The following is a description of a gene set: The postradiation tumor escape signature: genes up-regulated in tumors from irradiated stroma vs those from non-irradiated stroma. studied in species Mus musculus Human Gene Set: MONNIER_POSTRADIATION_TUMOR_ESCAPE_UP Radiotherapy is widely used to treat human cancer. Patients locally recurring after radiotherapy, however, have increased risk of metastatic progression and poor prognosis. The clinical management of postradiation recurrences remains an unresolved issue. Tumors growing in preirradiated tissues have an increased fraction of hypoxic cells and are more metastatic, a condition known as tumor bed effect. The transcription factor hypoxia inducible factor (HIF)-1 promotes invasion and metastasis of hypoxic tumors, but its role in the tumor bed effect has not been reported. Here, we show that tumor cells derived from SCCVII and HCT116 tumors growing in a preirradiated bed, or selected in vitro through repeated cycles of severe hypoxia, retain invasive and metastatic capacities when returned to normoxia. HIF activity, although facilitating metastatic spreading of tumors growing in a preirradiated bed, is not essential. Through gene expression profiling and gain- and loss-of-function experiments, we identified the matricellular protein CYR61 and alphaVbeta5 integrin as proteins cooperating to mediate these effects. The anti-alphaV integrin monoclonal antibody 17E6 and the small molecular alphaVbeta3/alphaVbeta5 integrin inhibitor EMD121974 suppressed invasion and metastasis induced by CYR61 and attenuated metastasis of tumors growing within a preirradiated field. These results represent a conceptual advance to the understanding of the tumor bed effect and identify CYR61 and alphaVbeta5 integrin as proteins that cooperate to mediate metastasis. They also identify alphaV integrin inhibition as a potential therapeutic approach for preventing metastasis in patients at risk for postradiation recurrences. from publication Monnier Y, Farmer P, Bieler G, Imaizumi N, Sengstag T, Alghisi GC, Stehle JC, Ciarloni L, Andrejevic-Blant S, Moeckli R, Mirimanoff RO, Goodman SL, Delorenzi M, Rüegg C (PMID 18794119), and this is the list of marker genes: RPAP1, RRP8, PRCP, PTPN11, FAM149A, INTS13, ZNF267, LRRC14, CGNL1, RAMP3, SCIN, AKAP1, PRKAR2B, SLC66A2, CAMK2D, KAT2A, SLC25A10, SPTBN1, TXNRD1, INTS2, SMAD1, CCNT1, SRM, TADA2B, XPO5, MAN1A1, G3BP2, PABPN1, RUNDC1 (NCBI Gene Id 146923), XPO4, SLC48A1, YAP1, FASTKD1, DHX9, FAM98A, NEMF, WIPF2, SLC25A44, PPM1F, AHRR, GON4L, NQO1, BNC2, HGH1, ZFYVE27, PNN, AK1, C5orf22, VCAN, ZNF335, TARDBP, SFPQ, NNMT, SLC39A6, FOSL1, FAAP24, EEIG1, MYBBP1A, GPC1, EREG (epiregulin), LRIG1, AQP5, ZKSCAN3, PDPR, AKR1B1, NHLRC2, ENPP2, HMGA1, ADIPOR1, AIRIM, OTUD7B, CRHR1 (corticotropin releasing hormone receptor 1), ZNF106, LONP1, RAPGEF6, ZMYND19, CLEC1A, CCL5, ALG10, CXCL6, DYNLL2, ERGIC1, MYD88, TNFAIP2, IL18R1, MSI2, CCDC93, MYBL2, ANKRD13A, DHX33, SMIM36, TFDP2 (transcription factor Dp-2, NCBI Gene Id 7029), IPO4, SEC22C, HIPK1, OXR1, ALKBH1, CLBA1, ZNF136, USP20, PRKCA, ATP1B1, DUSP9 (dual specificity phosphatase 9), NOA1, GREM1, GATAD2A, TSR1, NPLOC4, NAA25, SSX2IP, NOP9, ZNF121, ASS1, ASPH, AEBP1, WDR46, ZDHHC3, PTGS1, MLLT6, FAM53C, FAM83G, HNRNPK (NCBI Gene Id 3190), OTUD4, RAB5C, NMT2, SLC7A6, MAP2K3 (NCBI Gene Id 92079), DEPTOR, SMURF1, UBIAD1, SH3PXD2A, AVEN, RAPGEF1 (NCBI Gene Id 2889), TANGO6, SYNCRIP (synaptotagmin binding cytoplasmic RNA interacting protein), MTMR9, MYO10, MRPL15, AGO2, FDX1, PDCD11, LHFPL6, PMM2, MEI1, BAP1, ETV6, PABPC4, PDPN, KCNU1 (potassium calcium-activated channel subfamily U member 1), SNHG3, FTSJ3, RACK1, SREK1, BCAT1, RSRC2, TPM1, GRWD1, AEN, TRIM2, NCS1, MTDH, RAB8B, PPIF, SMARCC1, CSNK1G1, AP1AR, SEC23IP, GSR, GCLC, ZMAT3, LRRC59, SMG5, SCAI, DDX6, RCC1L, TRAF4, PPM1L, SOCS6, HSPA4L, SLC15A3, MLST8, ZFP91, CNTN2, SAMD4A, PGS1, GNG12, BLNK, PCBP2, ZC3H18, ILRUN, SMARCA4, SHROOM4, KCNK5, AMPD2, ELAC2, RBM25, KPNB1, GMPS, POLR1A, HSPA1B, BACE1, NOLC1, ODC1, MMP2, SPIRE2, GTF2H1, ZNF322, SLC12A2, ANKRD33B, PRMT6, SNORD52, TXN2, SUMO3, PIK3R1, LTBP1, UTP4, FAM32A, DYNC1LI2, RCC1, LUC7L3, PPP1R10, NOL8, PTDSS1, CDH5, POLDIP2, STRAP, CDK2AP1, PWP2 (NCBI Gene Id 5822), PRPF3, TRAF2, GEMIN5, FAM167B, SLC6A8, INO80E, MMD, METTL1, MTF2, RND1, ARGLU1, GSPT1, UBE2L3, DAP, MRGPRF, CCNB1IP1, CREBBP, PDE12, ABCE1, PRPF4, RBM14, ELP1, CDK8, ETS1, SRPRB, DUS3L, CDK6, SLMAP, ATP1A1, DDX54, EIF4G1, EIF4EBP2, G6PD, TRMT61A, RAB35 (RAB35, member RAS oncogene family), TEX261, ANXA11, NAA16, RRP7A, ABLIM1, LETM1, MAP3K7, MLEC, PC, CREBZF, EAF1, PNPLA6, NOP56, KCNQ1OT1, NAA15, TSPAN5, USP19, SLC35A4, ABCC1, TSC22D1, RASSF1, LYPD3 (NCBI Gene Id 94931), RBM19, ABITRAM (actin binding transcription modulator), PA2G4, PGD (NCBI Gene Id 5226), APH1A, ZMPSTE24, VPS33A, PRRX1, GOSR2, SLC19A1 (NCBI Gene Id 6573), IL1RL1, KMT5A, BTAF1, XDH, PPAT, KANSL2, MTR, SLC10A3, PPP1R12B (NCBI Gene Id 4660), BMS1, LTO1, TAOK1, TXLNA, IL11, RHOJ, PROSER1 (proline and serine rich 1), CENPA, RLIM, SLC35B4, MCC, GPD1L, GLS, URB2, TBRG4, DDX46, TTC39C, RAD23B, MAP4K4, ESPL1, RNF183, MAFG, SLC25A32, UACA, KIF21A, SELENOW, SLC11A2, MTHFD1, XPO6, SLC22A23, PDAP1, SNTB2, SGIP1, SUPV3L1, SENP2, TNS3, ASH2L, KHDC4, ACTR1B, RBM27, BRD2, GTF3C6, PDZRN3, SENP3, THOC3, TSPAN14 (NCBI Gene Id 91090), SDC1, TRMT6, RRP12, MRPS15, ETF1, HSPA4, INTS6, ATP2A2, DNMT3L, FAIM2, DDX3X, NFKBIE, TFRC, NRP1, LETMD1, ASRGL1, RWDD4, SMYD5, MARCKSL1, DDX51, PCYT1A, MFSD10, CCAR1, LBHD1, GLDC, SLC14A1, POP1, ATP2B1, ITPRIP, SDAD1, MARCHF5, NEAT1, NCBP1, MCMBP, FKBP4, PRR3, NIPBL, IAPP, VAT1, UBXN8, BOP1, EIF3B, SCAP, FASTKD3, TIRAP, GCLM, CFAP45, KCTD17, PIGL, EPB41L1, SLIT2, SLTM, OASL, TTPAL, BBX, SLCO3A1, CHD4